The following is a description of a gene set: Mouse Gene Set: GOCC_PHOSPHOLIPID_TRANSLOCATING_ATPASE_COMPLEX species: Mus musculus A protein complex that functions as a phospholipid-translocating P-Type ATPase., and this is the list of marker genes: Atp8a2, Atp10b, Atp11c, Atp11b, Tmem30b, Atp10d, Atp10a, Tmem30a, Atp8b1, Atp8b2, Atp8b4, Atp11a, Atp8a1